The following is a description of a gene set: species: Mus musculus Mouse Gene Set: GOCC_GATOR1_COMPLEX A GTPase-activating protein (GAP) complex that regulates TORC1 signaling by interacting with the Rag GTPase. In human, the GATOR1 complex consists of DEPDC5, NPRL2, and NPRL3. In S. cerevisiae, this complex is referred to as SEACIT and contains the Iml1p, Npr2p, and Npr3p proteins., and this is the list of marker genes: Nprl3, Szt2, Depdc5 (NCBI Gene Id 52284), Rraga, Nprl2